The following is a description of a gene set: from publication Lee Y, Awasthi A, Yosef N, Quintana FJ, Xiao S, Peters A, Wu C, Kleinewietfeld M, Kunder S, Hafler DA, Sobel RA, Regev A, Kuchroo VK (PMID 22961052) Human Gene Set: GSE39820_IL1B_IL6_VS_IL1B_IL6_IL23A_TREATED_CD4_TCELL_DN Genes down-regulated in comparison of untreated CD4 T cells treated with IL1B and IL6 versus those treated with IL1B, IL6 and IL23A. TGF-beta3 produced by developing Th17 cells induces highly pathogenic T cells that are functionally and molecularly distinct from TGF-beta1-induced Th17 cells. The microarray data represent a distinct molecular signature for pathogenic versus non-pathogenic Th17 cells. species: Homo sapiens, and this is the list of marker genes: FAM222A, FAP, PPP4R1 (NCBI Gene Id 9989), IRX6, MED12L, CORO2A, FXYD4, ARNT, THNSL2, EYA2, PPCS, FOXE3, SLC6A6, CPD, OBP2B, SYTL3, SGIP1, MAN2B2, IDI1, NFKBIZ, MBD2, MLF1, GPX7, ACE2, GCH1, MPP1, IL17A, BAHD1, DPP4, FAM83D, EPHX2, PRICKLE1, STX11, RIPOR3, KCNMB4, ACOT9, GPR161, VASH1, BCL11A, ZDHHC2, STARD4, KCNF1, ANXA11, LUM, JPH4 (junctophilin 4), ENPP2, RAMP3, EVI2A, CXCL1, PPIC (peptidylprolyl isomerase C, NCBI Gene Id 5480), NRBP1, SCFD2, SLIT1, EBF1, JPH1, NOTCH2, EPB41L4B, NCF2, DTWD1, ACSL6, CD44, TSPO2, SLC39A14, BCAS3, CA2, VIM, VASN, IL1RN, MYL12B, CTSF, ELK3, SCAF1, TAL2, GPR65, ATP8B4, METRNL, TMEM239, GAP43, CYP26A1, TFF1, SDCBP2, C1orf21, PDGFA, DUSP14, CHM, AREL1, INPP5B, FIRRE, ABCC4, IL22, FAM43A, ACYP2, AHNAK, MIF4GD, PRUNE1, FUT8, SERPINE1, CCDC71L, SMAD7, LTB4R, NRN1, CHST7, LDHC, CA5B, NIBAN2, FABP5, IL1R2, SPRY3, CCHCR1, GPR45, MBNL3, LTBP4, DISP1, SPTBN2, AK1, FAH, MRGPRG (NCBI Gene Id 386746), PARP1 (NCBI Gene Id 142), APOE, IGFBPL1 (NCBI Gene Id 347252), MEFV, STK10, TPBG, TMTC2, SCUBE3, FUT4, CIAPIN1, DGAT1, COBLL1, LRP6, TENT5A, RAX, STRA8, PERP, NMRK1, RABGAP1, LDLRAD4, FNBP1, PHYHIP, DLGAP1, MCTP2, MMAB, DKK4, GNB4, MORC2, FNDC1, PROCR, CLBA1, GPR183, CPNE2, C6orf132, BACH2, TASP1, RNASE10, TNFRSF25, CAPG, ELANE, MED30, TXK, SLC4A11, SLC38A3, CCSAP, CA13, VKORC1L1, ARL16, TUBA1A, LMTK3 (lemur tyrosine kinase 3), ASIC4, DEGS2, S1PR1, FCRL1, UBE3D, PTGER4, TRAPPC14, SMTNL1, DUSP4, TSSK6, RETREG1, TPRG1L, NR4A1, OSBPL3, VSIR, GALNT3, DENND5A, CD5L, CCR6, S1PR3 (NCBI Gene Id 414320), TMEM169, PPFIBP1, ALCAM, SPACA4, NGB, RASGRP3, HEBP2, GALNT2, CBY2, SERPINB1, RCSD1, PLCD4, PRKD3